The following is a description of a gene set: Human Gene Set: GOBP_REGULATION_OF_AUTOPHAGY_OF_MITOCHONDRION Any process that modulates the frequency, rate or extent of mitochondrion degradation by an autophagic process. species: Homo sapiens, and this is the list of marker genes: DELE1, GBA1, TIGAR, RBX1, CDC37, HAX1 (HCLS1 associated protein X-1), ADCY10, TSPO, FZD5, EIF2AK1, VPS13D, HDAC6, CERS1, FBXW7, FBXL4 (F-box and leucine rich repeat protein 4), TP53, STUB1, NOD2, USP36, PINK1, PRKN, BNIP3L (BCL2 interacting protein 3 like), HTRA2, TOMM7, PARL, UBE2A, TSC2, CAMKK2, GSK3A, SREBF2, PARK7, MUL1, FKBP8, VDAC1, USP30, PPTC7, AMBRA1, DNM1L (dynamin 1 like), HK2, SLC25A4, HTT, CSNK2A2, ATP13A2, HUWE1, VPS13C, FBXO7, SLC25A5, SREBF1, IRGM, CTTN, BNIP3, ATP5IF1, RNF41